The following is a description of a gene set: Human Gene Set: MIR6866_3P studied in species Homo sapiens Genes predicted to be targets of miRBase v22 microRNA hsa-miR-6866-3p in miRDB v6.0 with MirTarget v4 prediction scores > 80 (high confidence targets). from publication Chen Y, Wang X (PMID 31504780), and this is the list of marker genes: ZNF281, PHF3, STX18, KAT7, ZNF611, NBEA, BCL9, GPN1, SFXN1, GET4, GPATCH2L, XRCC5 (NCBI Gene Id 7520), TOMM70, FUBP3, DLG5, AP1S3, AFG1L, ZFP91, CPNE8, ZNF843, CYBRD1, ZC4H2, PTEN, OTUD1, SUZ12, ASXL3, JARID2, SOS1, SLC12A2, ENDOV, SLC22A3, CCNT2, BPGM, MEF2C, FNIP1, PCDH9, CRKL, TAPBP, TMEM128, WASHC4, FBXW7 (NCBI Gene Id 55294), COG5, TTC31, FAM200A, B3GALT2 (NCBI Gene Id 90195), C15orf39, ACVR2A, FGFR2, FGD5, CD2AP, SRSF7, NIPBL, SLC43A3, MAFB, HNRNPR, CAVIN2, CHST9, MARS2, AKT1S1, FOXN2, RSPO3, GPC6, ATXN7, SEMA4B, SPRED1, PHACTR2, EXOSC9, ZC3H12C, STX6 (syntaxin 6), LRRC1, CEP97, ILRUN (NCBI Gene Id 79138), PPP3R1